The following is a description of a gene set: Modulation of the activity of the enzyme cAMP-dependent protein kinase. species: Mus musculus Mouse Gene Set: GOMF_CAMP_DEPENDENT_PROTEIN_KINASE_REGULATOR_ACTIVITY, and this is the list of marker genes: Pkig, Smo, Prkar2b, Nos2 (nitric oxide synthase 2, inducible), Prkar2a, Prkag2, Prkar1a, Pkia, Pkib, Prkar1b